Given this list of marker genes TIMM17B, HSPD1, ABCB10, NPTX1, THEM4, COL6A1 (collagen type VI alpha 1 chain), MIR29C, HSPA4, SLC25A15, HIP1R (NCBI Gene Id 9026), UCP3, MTX1, SLC25A33, TRMT10B, CHCHD4, GFER, TST, TOMM70, SLC8B1, SLC25A26, TOMM22, BNIP3, SLC25A38, PMAIP1, CCDC51, MUL1, TIMM23, PNPT1, MPC1L, SFXN5, LRRK2, SLC25A5, ACAA2, AFG3L2, PPM1K, ROMO1, SLC35F6, TIMM29, TIMM8A, CHCHD10, TOMM20L, STARD3, ATF2, ZNF205 (NCBI Gene Id 7759), SLC25A40, ARHGAP11B, BCL2L11, PSEN2, SLC25A46, BID, SLC25A13, TOMM40, VPS35, TIMM44, BOK, SLC25A32, MAIP1, SLC25A29, HSP90AA1, CPT1A (NCBI Gene Id 1374), TMEM102, SLC25A52, SLC9A1, SPG7, SLC25A21, GSK3B, CAMK2A, TIMM10, MICU3, SLC25A39, MCUB, UCP2, MTX2, PMPCB, SLC25A37, GSK3A, SLC25A31, NOL3, RHOT2, GHITM, IER3 (NCBI Gene Id 91950), SLC25A23, AGK, HK2, MCUR1, TOMM5, ATP5IF1, SLC25A20, TIMM21, SLC30A2, TIMM23B, TMEM14A, CPT2, GRPEL1 (NCBI Gene Id 80273), VDAC1, SLC25A24, AIFM1, BNIP3L, TOMM7, TOMM40L, STPG1, ABCB8, TIMM8B, TIMM13, STAT3, NAIF1, RHOT1, SLC41A3, UCP1, SLC25A6, PSEN1, SLC25A2, FZD9, CPT1B, SLC25A16, SLC39A8, MRS2, DNAJC15, ITPR1, MPC1 (mitochondrial pyruvate carrier 1), MIR17, BLOC1S2, DNAJC19, GRPEL2, PRKN, SLC25A28, SLC25A41, EYA2, MPV17L, SIVA1, MICU2, HSPA9, MTCH1, ABCB7, FLVCR1, HSPA1A, TIMM50, TIMM9, ALKBH7, ADCY10 (NCBI Gene Id 82259), SLC25A3, SLC25A36, TOMM6, BHLHA15, PAM16, DNLZ (DNL-type zinc finger), TIMM10B, SAMM50, MRPL18, TP53, MIR29B1, BCL2, RTL10, VDAC2, BAX, TMEM14C, PPIF (NCBI Gene Id 10105), LETM2, SELENON, MIR29A, SLC25A1, SFXN3, MICU1, SMDT1, TIMM17A, MCU, SFXN4, BAD, SLC8A3, TOMM20, SFXN2, MPC2, GCLC, MTCH2, TIMM22, NDUFA13, SLC25A51, PINK1, SFXN1 (sideroflexin 1), SLC25A4, LETM1, BCL2L1, BAK1, here is a description of the gene set: species: Homo sapiens Transport of substances into, out of or within a mitochondrion. Human Gene Set: GOBP_MITOCHONDRIAL_TRANSPORT